Given this list of marker genes RECQL4, GLI3, LMBR1, SALL4, TRIO, TBX3 (T-box transcription factor 3), VAC14, SHH, TBX5, XRCC2, FANCD2, FIG4, here is a description of the gene set: Human Gene Set: HP_APLASIA_OF_METACARPAL_BONES studied in species Homo sapiens Developmental defect associated with absence of one or more metacarpal bones. Aplasia of metacarpal bones